The following is a description of a gene set: studied in species Mus musculus Mouse Gene Set: GOBP_MAMMARY_GLAND_ALVEOLUS_DEVELOPMENT The progression of the mammary gland alveolus over time, from its formation to its mature state. The mammary gland alveolus is a sac-like structure that is found in the mature gland., and this is the list of marker genes: Phb2, Foxb1, Areg, Hif1a, Agap2, Vegfa, Prlr (prolactin receptor), Tph1 (NCBI Gene Id 21990), Tnfrsf11a, Erbb4, Socs2, Hoxa5, Ccnd1, Ar, Ddr1 (discoidin domain receptor family, member 1), Id2, Chuk, Tgfa, Tnfsf11, Egf, Foxf1, Esr1